The following is a description of a gene set: Human Gene Set: HP_BIFID_EPIGLOTTIS A midline anterior-posterior cleft of the epiglottis that involves at least two-thirds of the epiglottic leaf. It is a useful feature for clinical diagnosis because it appears to be very rare in syndromes other than Pallister-Hall-Syndrome and is also rare as an isolated malformation. Bifid epiglottis studied in species Homo sapiens, and this is the list of marker genes: DYNC2I1, GLI3, WDR35, IFT80, DYNC2H1, DYNC2I2, FOXE1